Given this list of marker genes DCHS2, FGF4, ISL1, CTNNBIP1, PRRX1, WNT2, NFIB, MYC, SIX2, MSX1, LMNA, BMP4, DCHS1 (dachsous cadherin-related 1), MYCN, CTNNB1, IRS2, SOX9, GPC3, FGFR1, IHH, FOXF1, SHH, BMPR1A, FGF7, HAND2, SMO, STAT1, TBX1, FGF9, LRP5, ARHGAP5, FGFR2, PDGFA, CHRD, TBX2 (T-box transcription factor 2), TGFBR2, PHF14, ZEB1, KDR, WNT5A, BMP2, OSR1, SIX1, SHOX2, BMP7, FOXP2, WNT11, here is a description of the gene set: Human Gene Set: GOBP_MESENCHYMAL_CELL_PROLIFERATION species: Homo sapiens The multiplication or reproduction of cells, resulting in the expansion of a mesenchymal cell population. A mesenchymal cell is a cell that normally gives rise to other cells that are organized as three-dimensional masses, rather than sheets.